The following is a description of a gene set: from publication Chen Y, Wang X (PMID 31504780) studied in species Mus musculus Genes predicted to be targets of miRBase v22 microRNA mmu_miR_6971_5p in miRDB v6.0 with MirTarget v4 prediction scores > 80 (high confidence targets). Mouse Gene Set: MIR_6971_5P, and this is the list of marker genes: Pxn, Rph3a, Sp2, Nkx2-1, Notch4, Zfp395, Tulp1, Svil, Plekha2, Hspb7, Hmga1b, Diras1, Zfp637, Nacc1, Mgll, Asic1, Tsr1, Als2cl, Ccdc3, Tln2, Wdtc1, Rufy4, Dgkk, Fkbp8, D430041D05Rik, Wdr89, Cyp1b1, Nlgn2, Entrep2, Ppp1r9b, Hmga1, Slc1a1, Stk4 (serine/threonine kinase 4), Alx4, Dusp18, Celf5, Rhob, Sox12, Nova2, Mgme1, Rasl10b, Zscan10, Hsd17b8, Rab5c, Ncdn (neurochondrin), Nfasc, Usp4, Prr12, Kif14, Trim31, Atg7, Naaladl2, Mab21l2 (NCBI Gene Id 23937), Zfp950, Tmem178b, Yipf6, Zbtb4, Pvalb, Eral1, Gtf3c5, Tmt1a3, Pcbp2, Abtb1, Samd1, Capn6, Zdhhc15, Pbx2, Fam117b, Wnt5a, Wiz, Nfix, Ppp2r1a, Lrrc4c, Agbl3, Dlk1, Slc30a2, Map1a, Col1a1, Pde1b, Hras, Cbfa2t3, Pcyt1a, Tceanc2, Mex3a, Rab6b, Smarcc2, Crabp1, Ppm1n, Capzb, Lhx6 (NCBI Gene Id 16874), Rfx7, 2210016L21Rik, Rbfox2, Cplx1, Sap25 (sin3 associated polypeptide), Rnf14, Mecp2, Tmem151a, Ngp, Gsk3a, Slc6a17, Gnat1, Plagl2, Shisa9, Nfam1, Mest, Ppp4r3a, Col6a1, Dcx (NCBI Gene Id 13193), Dpp6, Cop1, Zfp710, Lrrc28, Mpp2, Pskh1, Ankrd49, Dhcr24, Rnf144a, Rxrg, Igf2bp1, Pknox2, Apba1, Snapin, 2310022A10Rik, Macrod2, Srrm4, Ctnnd1, Fam171b, Retreg3, Zfp593, Fam163b, Kcnc3, Pou3f2, C130074G19Rik, Sox9, Dyrk1a, Cdc37l1, Camk1d, Tead2, Pou2f2, Pax7, Psme3, Rnft2, Kmt2d, Ergic1, Impa1, Srsf3, Zfp703, Klf6